Given this list of marker genes LINC01596, HBG2, NDUFS3, ENSG00000229699, MT-TP, TUBB8P6, FMN2 (NCBI Gene Id 56776), LMNA, MIR302E, OR2T33, MIR4477A, ZC3H11B, KBTBD4, OR5M4P, MSNP1 (NCBI Gene Id 4479), LINC02782 (NCBI Gene Id 105376681), LINC01741, here is a description of the gene set: Genes containing one or more binding sites for (LAMB3) in their promoter regions (TSS -1000,+100 bp) as identified by GTRD version 20.06 ChIP-seq harmonization. from publication Yevshin I, Sharipov R, Kolmykov S, Kondrakhin Y, Kolpakov F (PMID 30445619) species: Homo sapiens Human Gene Set: LAMB3_TARGET_GENES